The following is a description of a gene set: Human Gene Set: MIR6715B_3P species: Homo sapiens from publication Chen Y, Wang X (PMID 31504780) Genes predicted to be targets of miRBase v22 microRNA hsa-miR-6715b-3p in miRDB v6.0 with MirTarget v4 prediction scores > 80 (high confidence targets)., and this is the list of marker genes: RAB29, IQCH, GSKIP, NCAPG2, RBM15B, AMMECR1, PLSCR5, INSR, SGIP1, SEPTIN11 (septin 11), STIMATE, ITFG1, RNF103, SYT1, SRSF2, CTDSP2, ZNF131, ING1, KLF3, TSPAN9, LCOR, SIRT5, HMGXB4, ELOVL5, ABITRAM, CRTAP, PABPC4, DPYSL3, DZIP1, RANBP6, STRBP, NPAT, PDIK1L (PDLIM1 interacting kinase 1 like), MAPK1, TMEM18 (NCBI Gene Id 129787), ZKSCAN5, PNPLA8, RNF180, KPNA4, CDC40, SNRPD1, ECT2, TENT4B, MICAL2, ADO, SIRT1, AMD1, NR4A3, ZBTB20, CDYL2, CBLL1, LY6K, SRP9, MINK1, EHBP1, ZMIZ1, JMY, CDS1, HOXA13 (NCBI Gene Id 3209), ABCC4, STX2, EIF3A, PTBP3, TGFBR3, CNOT6, AKIRIN1, FBXW7, FBXO30, CCN2, NCBP1, NUP37, NSA2, RGPD2, DYRK2, EIF5B, ACTR8, FARP1, FAM83D, CD5, EYA4, MTMR4, SSR3, ARID2, BBX (BBX high mobility group box domain containing), MEX3C, CDKL5, ALG6, TCERG1, MED13L, MFSD1, NUDT21, EIF4E, SRSF3, RBM20, MINDY3, GGCX, CRIM1, ENTPD1, ZNF214, MARF1, SORCS1, RNH1, KDELR3, ATXN7, NHS, DAZAP1, ZNF804A, SLC35A3, FAM161A, RO60, ST8SIA3, MS4A1, ATL2, ASPN, CTLA4, PABIR2, STEEP1, MAP2K5, MYO3B, PRDM1, MLPH, RAP2A, TBPL2, KLHL20, NECTIN3, CD163, CLDN5, TM9SF3, SDE2, NFIB (NCBI Gene Id 4781), FCRL1